The following is a description of a gene set: Human Gene Set: GOMF_ALCOHOL_BINDING Binding to an alcohol, any of a class of alkyl compounds containing a hydroxyl group. species: Homo sapiens, and this is the list of marker genes: APOD, GRAMD1B, ITPR2, APOF, PLCL2, NR1H3, STARD3NL, OSBPL6, OSBPL5, CRABP2, XPR1, SCP2, CD81 (NCBI Gene Id 975), RLBP1, STARD4, OSBPL7, NINJ2, ERLIN2, RBP3, ADAP2, TRPC1 (transient receptor potential cation channel subfamily C member 1), TSPO (NCBI Gene Id 706), TRPC3, CETP, RBP5, APOA2, PMP2, SLC38A9, SULT2B1, NPC2, RBP4, ABCG1, SIDT1, SOAT1, APOC3, ANXA6, NPC1L1, TRPC7, SOAT2, TPK1, TRPC4, OSBPL2, MTOR, APOA1, ADAP1, ITPR1, CAV1, ITPR3, GLE1, VDAC1, RPH3A, GRAMD1A, STAR, SYT2, STARD5, PTCH1, OSBPL8, PROM2, ADH4, CDIPT, CYP27C1, DPM1, PROM1, LRAT, RBP1, OSBPL1A, ERLIN1, OSBPL10, SCARB2, STARD3 (NCBI Gene Id 10948), RBP2, OSBPL3, GPR155, OSBP2, PRKCE, TSPO2, TMEM97, STRA6, TRPC5, CYP2W1, ABCA1, CYTH2, CRABP1, RBP7, TRPC6, ASTN2, C8G, SYP, NPC1, ADH7, NFE2L1, MINAR2, GRAMD1C, VDAC2